Given this list of marker genes Gm15074, Gucy2f, Gm15014, Mir448, Mir1911, Gm15127, Gm15112, Hmgn2l6, Gm25107 (NCBI Gene Id 115486124), Gm15048, Il13ra2, Chrdl1, Acsl4, Hmgb1-ps2, Irs4, Gm15032, Gm15128 (predicted gene 15128), Rtl9, Ammecr1, Mir652, Gm15110, Col4a6, Gm5762, Gm15031, Gm7123, Gm25097, Gm25915, Col4a5, Gm15060, Gm8331, Trpc5os, Gm15295, Gm15061, Sertm2, Gm4996, Trpc5, Gm15106, Gm15113, Pou5f1-rs13, Kars1-ps1, Gm15066, Rtl4, Vmn1r239-ps, Gm23325, Gm15073, Kcne5, Gm6067, Gm15125, Gm5763, Gm15126, Amot, Nxt2, Gm15057, Mir1912, Gm6446, Gm8216, Gm15109, Gm8202 (predicted gene 8202), Gm6368, Dcx, Tmem164, Gm8320, Pak3, Mir764, Gm15067 (predicted gene 15067), Alg13, Mir3552, Snora35, Lhfpl1, Gm6373 (predicted gene 6373), Gm4918, Mir1264, Gm5644, Gm15081, Gm8289, Gm4995, Htr2c, Gm8303, Gm6441, Gm15114, Gm15075, Gm6382, Gm16400, Gm5643, Gm15107, Gm8334, Gm4760, Lrch2, Mir1298, Gm6447, Gm15080, Capn6, Gm15071, Mageb16-ps1, Gm8261, Gm15294, Gm8199, Gm2214, here is a description of the gene set: Mouse Gene Set: chrXF2 studied in species Mus musculus